Given this list of marker genes TRIM33, BMP4, FOXH1, GSC, EOMES, NANOG, POU5F1, LEF1, TCF7, CTNNB1, SMAD2, SOX2, TBXT, SMAD3, SMAD4, MIXL1, TBPL2, here is a description of the gene set: Human Gene Set: REACTOME_GERM_LAYER_FORMATION_AT_GASTRULATION studied in species Homo sapiens Germ layer formation at gastrulation